The following is a description of a gene set: Mouse Gene Set: GOMF_ACYLTRANSFERASE_ACTIVITY species: Mus musculus Catalysis of the transfer of an acyl group from one compound (donor) to another (acceptor)., and this is the list of marker genes: Fbxo2, Klhl13, Ube4a, Tnfaip3, Pafah2, Hectd3, Bspry, Serinc1, Zmiz1, Nat2, Brca2, Ring1, Arih2, Nccrp1, Trim24, Rnf38, Sh3rf1, Trim14, Trim9, Trim2, Lpcat3, Trim71 (NCBI Gene Id 72491), Pcgf2, Cbll1, Pcgf3, Malt1, Prdx6b, Sptlc3, Acaa2, Marchf5, Lonrf2 (NCBI Gene Id 98460), Marchf2, Rmnd5b, Klhl9, Trim6, Traf3, Med20, Ube2f, Rpl37, Rnf41, Rpl11, Zdhhc1, Trim17, Sirt7, Naa12, Zdhhc16, Ube2h, Naa80, Pla2g4c, Tmem129, Cdkn1b, Traip, Cdkn2a, Rpgr, Wdr24, Herc3, Tgm3, Rnf212b, Nat1, Fbxo40, Slc27a3 (solute carrier family 27 (fatty acid transporter), member 3), Rnf40, Shprh, Kctd13, Mycbp2 (NCBI Gene Id 97940), Osgep, Glul, Sirt1, Spry2, Trim68, Rnf125, Aktip, Nt5c2, Cdc20, Rnf10, Nat10, Ube2l3, Mgrn1, Rnf111, Trim43c, Cdc20b, Dgat2, Cul3, Abhd14b, Ncoa3, Fbxo6, Vps11, D7Ertd443e, Mboat2 (NCBI Gene Id 67216), Msl2, Fbxo30, Ubr7, Dzip3, Rnf4, Klhl20, Naa11, Trim31, Ube2z, Med31, Ube2c, Dlat, Trim32, Naa10, Birc6, Sh3rf3, Pafah1b3, Rnf31, Trim41, Marchf11, Ube2q2l, Ubr4, Chat, Asb12 (NCBI Gene Id 70392), Crat, Agpat3, Abhd5, Znrf2, Rfwd3, Dtx2, Epb42, Ifnb1, Lclat1, Rnf128, Sat2, Trim55, Nat8f2, Trim3, Tnfaip1, Cpt1c, Hadha, Gid4, Rpl37rt, Rpl5, Nhlrc1, Jade1, G2e3, Rnf7, Rnf8, Park7, Trim12a (tripartite motif-containing 12A), Mex3c, Ube2dnl2, Bcor, Pja1, Acat1, Lpgat1, Acat2, Dcst1, Zmiz2, Zdhhc12, Ykt6 (NCBI Gene Id 80527), Tafazzin, Pdcd5, Fbxl22, Sh3glb1, Ube2e1, Naa50, Med24, Nupr1, Abhd4, Rnf208, Tlcd3b, Zdhhc2, Mboat4, Rnf141, Pias4, Nedd4l, Gnpat, Zfp598, Rbck1, Brap, Sirt5, Serinc5, Trim21, Bcas3, Zdhhc20, Rnf39, Pafah1b2 (platelet-activating factor acetylhydrolase, isoform 1b, subunit 2), Ube2k, Cdk8, Med23, Asb2, Elovl5, Dbt, Rnf185, Ube2e2, Trim39, Dtx4, Mkrn3, Med27, Rmnd5a, Pten, Cul4a, Wsb1, Bmi1, Pias3, Ube2e3, Marchf8, Trim40, Acaa1b, Agpat2, Cop1, Rnf13, Rnf139 (ring finger protein 139), Pex12, Trim7, Pias2, Lcat, Lnx1, Trim11, Katna1, Crot, Kctd10, Dtx3, Trim62, Kat2a, Cln5, Rnf144b, Ube2g1 (ubiquitin-conjugating enzyme E2G 1), Rnf25, Egr2, Entrep1, Kat7, Amfr, Dtl, Ube2d3, Sumo2, Rnf170, Cracr2b, Siah2, Atg12, Apoe, Ube2v1, Mdm2, Ube2d4, Rnf122, Usp22, Prkn, Trim38, Mcm3ap, Qpct, Ncoa1, Rnf169, Rnf212, Pla2g4a, Cpt2 (NCBI Gene Id 12896), Pdzrn3, Atg5, Dgat1 (diacylglycerol O-acyltransferase 1), Gpat3, Asb4, Lipt1, Casd1, Med18, Fbxo4, Rnf166, Zdhhc14, Cers2, Peli2, Tada2a, Pja2, Trim30b, Rnf5, Cnot4, Ogt, Acsm5, Nat9, Ubr5, Uhrf1, Ube2r2, Msx3, Pias1, Fbxl3, Btrc, Uba7, Zdhhc6, Bard1, Marchf1, Glyat, Mettl8, Rnf19b, Rnf7l, Acaa1a, Alas2, Clybl, Acsm4, Ube2srt (ubiquitin-conjugating enzyme E2S, retrotransposed), Ube2m, Hmgcs1, Pml, Keg1, Ube2j2, Marchf9, Wwp1, Nat8f1, Trim35, Rnf144a, Fbxw8, Nat8f3, Gtf2b, Zdhhc22, Zdhhc11, Zdhhc5, Trim43a, Nat8f7, Rbx1, Trim36, Rabgef1 (NCBI Gene Id 56715), Sirt4, Pcgf5, Rnf2, Uhrf2 (NCBI Gene Id 76468), Zdhhc15, Clock, Rnf43, Rad18, Nat14, Rnf115, Gm4952, Obi1, Fbxo11, Cbx4, Marchf7, Htra2, Meaf6, Oacyl, Birc7, Gpat4, Rnf168, Skp1, Trim43b, Phf10, Zzef1, Mdm4 (NCBI Gene Id 98570), Nosip, Hace1, Qpctl, Trim28, Med11, Ube3a, Ufc1 (NCBI Gene Id 66155), Kat14, Gnpnat1, Abhd8, Rchy1, Syvn1, Ube3b, Trip12, Limk1, Rfpl4, Marchf3, Marchf4, Kat8, Hectd2, Awat2, Trim27 (NCBI Gene Id 19720), Lpcat1, Osgepl1, Ubr1, Trim34b, Lipc, Zdhhc8, Zdhhc4, Cers3, Peli3, Smurf2, Zdhhc17, Fancl, Trib2, Hadhb, Ube2d2b, Zdhhc24, Rnf157, Rnf214, Hat1, Arih1, Traf5 (NCBI Gene Id 622602), Fancf, Atf2, Fbxo15, Med6, Elp3, Nedd4, Rps7, Stub1, Soat2, Rnf138, Sphk1, Taf10, Herc4, Rnf215, Trim72, Neurl1b, Rnf180 (NCBI Gene Id 71816), Herc6, Cpt1b, Porcn, Ing4, Neurl1a, Ufl1, Rnf113a1, Brca1, Trim63, Pin1rt1, Rnf113a2, Rpl23, Brpf1, Apoa2, Ube2u, Mefv (NCBI Gene Id 54483), Klhl42, Baat, Elovl1 (ELOVL fatty acid elongase 1), Aurkaip1, Naa15, Sat1, Agpat4, Hecw1, Rnf181, Med21, Rnf146, Ube2d2a (NCBI Gene Id 80608), Nsmce2, Naa60, Ube2o, Neurl3, Soat1, Rc3h2, Fbxo5, Ggt6, Itch, Cpt1a, Elovl7, Elovl4, Mkrn2, Dgat2l6, Rc3h1, Trim13, Hdac4, Wwp2 (WW domain containing E3 ubiquitin protein ligase 2), Sptssa, Ube2j1, Prdx6, Lpcat4, Apoa5, Klhl21, Otub1, Pin1, Lpcat2b (NCBI Gene Id 70902), Tmem68, Ube3c, Tgm5, Rnf213, Rnf148, Ggt1, Acnat2, Pla2g4e (phospholipase A2, group IVE), Trim45, Zdhhc3, Rnf26rt, Trim50, Rnf217, Znrf3, Rnft2, Peli1, Rnf225, Arel1, Taf9, Kat2b, Rnf123, Ube2d1, Fbxl14, Trim26, Ark2n, Tgm7, Siah1b, Nat8f5, Zswim2, Trim61, Hecw2, Nags, Trim37, Cdc34b (NCBI Gene Id 53980), Trim30d, Cs, Ttc3, Zfp91, Fasn, Cdc42, Ep300 (NCBI Gene Id 328572), Toporsl, Nmt1, Nat8, Apoa1, Rbbp6, Mkrn1, Kat6a, Vps18, Mib1, Dtx3l, Trim12c, Pex10, Elovl2, Mogat1 (monoacylglycerol O-acyltransferase 1), Rlim, Scp2 (sterol carrier protein 2, liver), Rps20, Rps15, Rnf6, Huwe1, Pygo2, Bfar, Mboat7, Smurf1, Alas1 (NCBI Gene Id 57445), Neurl2, Trim60, Trib3, Pigw, Rnf187, Acly, Rnf26, Rnf183, Cdc34, Zfp451, Hgsnat, Traf3ip2, Tgm4, Rspry1, Rnf130, Ube2a, Rbx1-ps, Trim30a, Gbp4, Oxsm, Lpcat2, Siah3 (NCBI Gene Id 380918), Lipt2, Ube2n (ubiquitin-conjugating enzyme E2N), Ube4b, Nfx1, Plaat1, Ubr3 (NCBI Gene Id 99175), Ube2g2, Lrsam1, Naa16, Trim56, Hhat, Naa30, Trim30c, Fbxo44, Hltf (helicase-like transcription factor), Rnf112, Zdhhc9, Ubr2, Cbx8, Trim5, Sirt6, Atg3, Trim44, Kcmf1, Trim23, Brpf3, Rag1, Zdhhc18, Ube2i, Nat8b-ps, Agpat1, Med7, Asb1, Nap1l2, Sptssb, Ube2frt, Nmt2, Elovl3, Trim52, Med10, Mib2, Aanat, Ube2q1, Znrf1, Rnf220, Triml1, Cbl, Esco2 (establishment of sister chromatid cohesion N-acetyltransferase 2), Trim25 (NCBI Gene Id 22660), Naa40, Topors, Pnpla2, Gm6993, Sptlc2, Hdac6, Acsm1, Rnf133, Apoa4, Trim47, Dtx1, Ankib1, Nat8f6, Prpf19, Trim58, Zdhhc19, Chfr, Irf2bp1, Trim33, Sirt2, Mboat1, Fbxo27, Rnf114 (NCBI Gene Id 99401), Naa25, Crebbp, Ccnc, Cblb, Cers4, Kat5, Rnf149, Pnpla1, Hectd1, Mogat2, Rnft1, Med30, Trim10, Rnf182, Kmt2c, Atg10, Acat3, Rnf11, Trim75, Nhlrc3, Fbxw7, Rnf150, Jade2, Rffl, Ercc8, Agpat5, Rnf126, Rnf227, Naa20, Gpat2, Mylip, Gcat, Zdhhc25, Lrat, Med1, Ppp1r11 (NCBI Gene Id 76497), Gtf3c4, Herc2, Gcn1, Ggt7, Trim15 (NCBI Gene Id 69097), Rnf19a, Ranbp2, Fbxo17, Med12, Zdhhc7, Rnf186, Nat8l, Pla2g15, Ciita (class II transactivator), Rnf121, Pex2, Fcor, Bloc1s1, Traf2, Plaat5, Dlst, Mcat, Rnf145, Marchf6 (NCBI Gene Id 223455), Map3k1, Zdhhc13, Kat6b, Acnat1, Sptlc1, Ggt5, Ube2b, Cers5, Rnf20, Ube2t, Zdhhc21, Sharpin, Ccnb1ip1, Ube2q2, Nat8f4 (NCBI Gene Id 75541), Znrf4, Trim65, Glyatl3, Rnf135, Wdsub1, Elovl6, Ube2w, Trim54, Med17, Trib1, Sh3rf2, Ube2l6, Ppil2, Birc2, Nat3, Rnf167, Rnf152, Atat1, Pnpla3, Ddb2, Trim34a, Tgm6 (NCBI Gene Id 241636), Ark2c, Rnf34, Tgm2, Trim8, Glmn, Aspg, Rnf223 (NCBI Gene Id 435821, ring finger 223), Cers1 (NCBI Gene Id 93898), F13a1, Csl, Trim69, Birc5, Gpam, Ube2s, Ube2dnl1, Anapc11, Rnf103, Hmgcs2, Cul1, Birc3, Irf2bpl, Awat1, Ate1, Rnf138rt1, Ube2ql1, Cblc, Cdyl (NCBI Gene Id 12593), Siah1a, Rnf44, Pdhx, Rnf14, Magel2, Trim59, Fbxw11, Neurl4, Lnx2, Acsm3, Zdhhc23, Pdcd5-ps, Acsm2, Cers6, Traf7, Nsmce1, Ubox5, Sumo3, Smarce1, Fzr1, Plaat3, Ing3, Esco1, Traf6, Taf1, Oga, Rnf216, Maea, Satl1, Brd1, Triml2, Sirt3, Ltn1, Ube3d, Xiap, Mul1, Tgm1